The following is a description of a gene set: studied in species Homo sapiens Human Gene Set: GOBP_STEM_CELL_FATE_SPECIFICATION The process in which a cell becomes capable of differentiating autonomously into a stem cell in an environment that is neutral with respect to the developmental pathway. Upon specification, the cell fate can be reversed., and this is the list of marker genes: SOX17, SOX9, GSC, SFRP2, DMRTA2, SOX18